The following is a description of a gene set: Like Cyclin A, NIMA-related kinase 2A (Nek2A) is degraded during pro-metaphase in a checkpoint-independent manner. studied in species Homo sapiens Reactome Pathway: APC-Cdc20 mediated degradation of Nek2A part of: APC:Cdc20 mediated degradation of cell cycle proteins prior to satisfation of the cell cycle checkpoint, and this is the list of marker genes: ANAPC11, ANAPC4, RPS27A, CDC27, ANAPC15, UBC, ANAPC16, ANAPC7, NEK2, UBE2E1, UBE2S, ANAPC5, CDC26, CDC16, UBE2C, ANAPC2, UBA52, CDC20, BUB1B, UBB, BUB3, ANAPC10, CDC23, UBE2D1, ANAPC1, MAD2L1